The following is a description of a gene set: Catalysis of the reaction: adenosine + H2O = inosine + NH3, in a tRNA molecule. Human Gene Set: GOMF_TRNA_SPECIFIC_ADENOSINE_DEAMINASE_ACTIVITY studied in species Homo sapiens, and this is the list of marker genes: ADARB1, ADAR, ADARB2, ADAT2, ADAT1, ADAD2, ADAD1, ADAT3